The following is a description of a gene set: Mouse Gene Set: GOBP_RESPONSE_TO_STILBENOID Any process that results in a change in state or activity of a cell or an organism (in terms of movement, secretion, enzyme production, gene expression, etc.) as a result of exposure to a stilbenoid. Stilbenoids are secondary products of heartwood formation in trees that can act as phytoalexins. Stilbenoids are hydroxylated derivatives of stilbene. They belong to the family of phenylpropanoids and share most of their biosynthesis pathway with chalcones. species: Mus musculus, and this is the list of marker genes: Ly6d, Cyp2a4 (NCBI Gene Id 13086), Slc22a7, Ifit3 (NCBI Gene Id 433243), Cyp2a5, Gsta1, Kcnj11, Saa3 (serum amyloid A 3), Slco1a1, Hba-a1, Apoa4, Hsd3b4, Sirt1 (NCBI Gene Id 93759), Idi1, Usp18, Mup3, Cidea, Fgl1, Cd36, Cyp2b9, Hsd3b5, Gsta2, Saa2, Kcnj8, Mup1